Given this list of marker genes Exosc4 (NCBI Gene Id 76326), Exosc10, Exosc8, Exosc2, Exosc3, Exosc1, Exosc7, Exosc5, Exosc6, Exosc9, here is a description of the gene set: Mouse Gene Set: GOCC_NUCLEOLAR_EXOSOME_RNASE_COMPLEX A ribonuclease complex that has 3-prime to 5-prime distributive hydrolytic exoribonuclease activity and in some taxa (e.g. yeast) endoribonuclease activity, producing 5-prime-phosphomonoesters. Participates in a multitude of cellular RNA processing and degradation events preventing nuclear export and/or translation of aberrant RNAs. Restricted to processing linear and circular single-stranded RNAs (ssRNA) only. RNAs with complex secondary structures may have to be unwound or pre-processed by co-factors prior to entering the complex, esp if the 3-prime end is structured. species: Mus musculus